Given this list of marker genes SLC22A5, SLC22A15, SLC22A2, SLC44A4, SLC22A3, SLC22A16 (solute carrier family 22 member 16), SLC6A14, SLC7A6, SLC22A4, SLC6A12, PDZK1, SLC16A9, SLC6A20, SLC25A19, SLC38A2, SLC25A20, SLC25A29, SLC22A1, here is a description of the gene set: The directed movement into, out of or within a cell, or between cells, by means of some agent such as a transporter or pore of quaternary ammonium compounds, any compound that can be regarded as derived from ammonium hydroxide or an ammonium salt by replacement of all four hydrogen atoms of the NH4+ ion by organic groups. Human Gene Set: GOBP_QUATERNARY_AMMONIUM_GROUP_TRANSPORT studied in species Homo sapiens